The following is a description of a gene set: studied in species Mus musculus Any process that results in a change in state or activity of an organism (in terms of movement, secretion, enzyme production, gene expression, etc.) as a result of a bacterial lipoprotein stimulus. Mouse Gene Set: GOBP_RESPONSE_TO_BACTERIAL_LIPOPROTEIN, and this is the list of marker genes: Tlr2, Tlr6, Ssc5d, Cd14, Cd36, Tlr1, Tirap